The following is a description of a gene set: species: Homo sapiens from publication Chen Y, Wang X (PMID 31504780) Human Gene Set: MIR4326 Genes predicted to be targets of miRBase v22 microRNA hsa-miR-4326 in miRDB v6.0 with MirTarget v4 prediction scores > 80 (high confidence targets)., and this is the list of marker genes: ATG2B, UBE3B, CNTD1, MXRA5 (matrix remodeling associated 5), EPHA3 (EPH receptor A3), CALU, RBM41, RHO, SH3TC2, CAB39, CTSB, C17orf107, RAB3IP, SMUG1, MAP3K13, GTF3C4, MEGF10, PROX1, TPX2, KLK15, C1QTNF3, KIF26B, YEATS4, SYDE2, CNRIP1, HDAC9, GPRC5C, PPM1M, SVOPL, SNAP23, ARHGAP35, TEX35, GTF2A1, FAM149A, HSF5, MBTPS1, ADAMTS5, GREB1, SLC25A53, CXADR, INCENP, CHM, GPR39, SUSD6, TCF21, ZNF790, TNP2 (transition protein 2), DOCK8, YIPF6, MRPS33, SAMSN1, SMC1A, C1GALT1, SPTLC1, SP100, TANGO2, TAB2, INPP4B, CCNY, UNC5CL, GABRG1, XIRP2, MED13, TSC1, ZNF559, LRRN2, ZRANB1, MPDZ, PDIA3, OLFM1, MAP3K2, ADAM28 (ADAM metallopeptidase domain 28), EIF2AK2, CLEC12B, UQCC1, CLSTN2 (NCBI Gene Id 64084), PRELP, ZNF304, RAB39B, CXCL14, MAPK13, LEMD3, GLTP, FAM124B, NBPF11